The following is a description of a gene set: species: Homo sapiens Human Gene Set: HP_RETINAL_DYSTROPHY Retinal dystrophy is an abnormality of the retina associated with a hereditary process. Retinal dystrophies are defined by their predominantly monogenic inheritance and they are frequently associated with loss or dysfunction of photoreceptor cells as a primary or secondary event. Retinal dystrophy, and this is the list of marker genes: RP9, ADAM9, NEK10 (NCBI Gene Id 375328), USH1G, IMPG1, B4GAT1, MT-ATP6, PMM2 (NCBI Gene Id 5373), NEK1, PEX2 (peroxisomal biogenesis factor 2), ITM2B, GRK1, CC2D2A, NDUFA9, CACNA1F, CDH23, PROM1, HACE1, RSPH3, TMEM216, GAS2L2, SLC7A14, DNAH5, EFEMP1, ARL2, PIBF1, CFI, FSCN2, IMPDH1, ERCC8, MT-TW (NCBI Gene Id 4578), FKTN, ZNF513, DNAI2, KIF11, IFT122, HCCS, CTSD, LRIT3, CLN3, AHR, COX7B, DRC1, PEX13, UBE3B, FOXJ1, ADGRV1, KCNV2 (NCBI Gene Id 169522), TRAF3IP1 (NCBI Gene Id 26146), ZNF408, RRM2B, TULP1, NYX, DNAAF3, ATP5MK, PRPF8, KIF3B, TOPORS, ARMC9, ALMS1, MT-ATP8, CEP41, NRL, CCDC28B, PGK1, RSPH9, GGCX, GPR179, BBS7, RDH12, CFAP74, MTTP, MYO7A, IDH3B, BMP4, CLDN19, MT-ND1, CERKL, DHX38, ODAD4 (outer dynein arm docking complex subunit 4), LAMA1, POMT2, CCDC39, CFAP298, TUB, TRIM32, LRP2, VPS13B, ATXN7, BBIP1, APOB, NPHP3, TRNT1, TRAPPC9, RXYLT1, DNAH9 (dynein axonemal heavy chain 9), SPEF2, DHDDS, CTNNA1, PDE6C, CFAP410, VWA8, DAG1, NDUFB11, DPAGT1, MCIDAS, IFT140, CLRN1, AMACR, RP1, RBP3, KIAA0586 (KIAA0586), NDUFA1, ATXN2, DNAAF4, ROM1, RLBP1, PDE6H, DRAM2, PRPS1, HYDIN, TMEM237, RPL10, RAX2, MPV17, MYO6, REEP6, GRN, RP1L1, TRIP13, SIX6, MKS1, CWC27, PEX1, PEX7, BBS9, MT-TL1, CLCN3, CSPP1, AHI1, CRX, HSPD1, RPGR (NCBI Gene Id 6110), USH1C, PDE6A, MT-ND4, OFD1, AGBL5, CCNQ (NCBI Gene Id 92002), FDXR, TTLL5, MDH2, PEX3, ELOVL4, WDPCP, POGZ, DNAAF5, TELO2, GNAT1, LRRC56, EYS, ZNF423, MERTK, LAMB2 (NCBI Gene Id 3913), IQCB1, PCARE, CHST6, SPAG1, MVK, ARL2BP, ATP5F1A, CFAP418, KIZ, MYO5A, GRM6, AHDC1, PNPLA6, DNAAF2, RP2, PPP2R3C, WHRN, CNNM4, BBS2, TMEM138, PIGA, CRPPA, CEP164, DYNC2I2, LARGE1, BBS10, NME8, MAK, TTC8, TMEM218, LZTFL1, DDR2, PDE6B, RAB28, PEX26, GUCA1A, RSPH1 (radial spoke head component 1), RCBTB1, ATP5F1D, PEX10, CIB2, COL4A1, ACBD5, CABP4, PRPF3, ODAD2, TMEM67, DNAAF11, ZPR1, LRAT, ACOX1, RPE65, DNAJB13, BBS1, CDHR1, PEX16, ALPK1, CEP120, TRPM1, WARS2, STK36, PCYT1A, NR2E3, SRD5A3, RPGRIP1L (NCBI Gene Id 23322), GUCY2D, INPP5E, RHO, GUCA1B, PRPF6, POMGNT2, B3GALNT2, HMX1, NGLY1, IFT74, INTS11, GNB3, SCAPER, SLC35A2, PGAP1, UNC119, MT-ND3, CNGB1, ABHD12, ARL3, HSD17B10, TUBGCP6, ARV1, USH2A, WDR19, HID1, PEX5, CACNA2D4, SLC24A1, ATPAF2, MT-ND2, RNF113A, ATP5F1E, DNAAF1, ACO2, PRPH2, PDE6G, ARL6, RDH11, SCLT1, RNU4ATAC, BBS5, CDH3, DNAH11, ODAD1, RDH5, SEMA4A, CFAP221, PEX19, COQ2, NEK2, FLVCR1, NPHP1, ZMYND10, RPGRIP1, PEX14, CNGA1, PEX12, ASPA, AIPL1, DNAAF6, DNAI1, MT-ND5, SLC19A2, MT-TV, KIF5A, CEP19, SAG, INVS, SYCE1, POMT1, RBP4, HK1, CRYAB, CCNO, IFT172, BBS12, MT-TK, PEX11B, GATA3, SH2B1, ATP2B2, MT-ND6, BBS4, FAM161A, TMEM231, PRPF31, CFAP300, HGSNAT, FGFR2, ERCC6, MAPKAPK3, PITPNM3, EXOSC3, NME5, MFSD8, MSRB3, CCDC40, ABCA4, BEST1, KLHL7, ALG6, TTC12, POMK, OTX2, AP3B2, EXOSC2 (NCBI Gene Id 23404), TIMP3, POC1B, IMPG2, CEP290, PANK2, BCS1L, DNAH1, PRCD, NPHP4 (nephrocystin 4), PEX6, SNRNP200, RGR, MKKS, PHYH, CRB1, IFT27, PRPF4, PDZD7, FKRP, DNAJC21, DNAL1, ODAD3, RSPH4A, CFH, PCDH15, POMGNT1, SAMD7, ANK1, VPS4A, SDCCAG8